Given this list of marker genes RGS17, RNF32, PRKCE, IFNA2, ABCC9, PCDH11X (protocadherin 11 X-linked), BTBD7, MAPRE1, FGGY (NCBI Gene Id 55277), IKZF2, EN2, CYRIB, TRIQK, PTPRD, GNE (glucosamine (UDP-N-acetyl)-2-epimerase/N-acetylmannosamine kinase), GATA6, RASSF3, SARNP, ADIPOR2, BLTP1, USF1, FOXO4, CBL, FCHSD2, ITGA6, INO80D, ZCRB1, MAP2K1, MOCS1, TP53INP1, COL4A3 (NCBI Gene Id 200750), METTL8, ERC2, CCSER2, CCNJL, RTF1, PRSS45P, GNG5, CAMTA1, WSB2, NAPB, COX18, WWP2 (NCBI Gene Id 116013), EDEM1, DMRT2, VAMP7, DDX42, PDS5A, ANKRD44, ARK2N, NAT8L (NCBI Gene Id 339984), SATB2, MBNL3, SLC25A36, CACNA1B, LCOR, MAP3K1, GRB10, PHOX2B, SMCO4, PCDH11Y, TTPA, IFNA1, PTGER3, IBSP, PSD2, PDSS1, SPIN1, RYBP, SLC16A14, INSYN2A, VAMP1, CAPNS2, TRIO, COX20, SORT1, PRDM1, RNF38, FSBP, RLF, CLCN4, SERTAD2, TCEAL5, DDHD2, CD36, GPR173, MAP2K4, GALNT16, CD69, HTATSF1, TCEAL2, GPR158, WDHD1, DHX36, PTPRJ, SCARA3, PDCD6, BOD1L1, COX19, DAAM1, SLC1A6, CPEB2, FAM83G, JPH1, CTNND2, PTPRK, SPMIP1, APPL1, KCND2, IL33, PPP3CA, CCNT2, MAP4K4, CBR4, SPARCL1, TM9SF2, SOCS5, TFDP2, YIPF6, TNKS, ALG2, TNRC6B, LEMD3, RAD54B, LYST, TET2, CNMD, AKAP13, CHRNG, SYT4, EPC1, ZFAND5, JMY, TCF7L2, TNFRSF9, CNOT6L, ST18, PPP3CB, CCDC169, DNAJC1, LPGAT1, ABR, GPM6B, PASK, SLC5A7, ZBTB10, GPR78, PLEKHG4, SPCS2, RRN3, RXFP1, MAP2, TMEM30A, CIC, ARHGEF3, ADGRA1, PRDM2, POTEM, ARL8B, ELK4, ACVR1B, FRS2, MAU2, KCNQ5, PJA2, HPSE2, KBTBD12, DAGLA, PPARGC1B, PRDM15, here is a description of the gene set: from publication Chen Y, Wang X (PMID 31504780) species: Homo sapiens Human Gene Set: MIR5589_3P Genes predicted to be targets of miRBase v22 microRNA hsa-miR-5589-3p in miRDB v6.0 with MirTarget v4 prediction scores > 80 (high confidence targets).